The following is a description of a gene set: Any process that modulates the rate, frequency or extent of keratinocyte proliferation. Keratinocyte proliferation is the multiplication or reproduction of keratinocytes, resulting in the expansion of a cell population. species: Mus musculus Mouse Gene Set: GOBP_REGULATION_OF_KERATINOCYTE_PROLIFERATION, and this is the list of marker genes: Irf6, Med1, Kdf1, Klf9, Fgfr2, Ift80, Lrg1, Tgm1, Bcl11b, Ift172, Ovol1, Crnn, Ptprk (protein tyrosine phosphatase receptor type K), Intu, Prkd1, Nfatc1, Efnb2, Kif3a, Trp63, Ctsl, Snai2, Ift122, Slurp1, Mdk, Notch2, Reg3a, Ift88, Eppk1, Extl3 (exostosin-like glycosyltransferase 3), Ift74, Vdr, Ovol2, Sfn (NCBI Gene Id 55948), Fgf10, Stxbp4, Cdh3 (cadherin 3), Reg3g, Srsf6, Has2, Gpr15lg, Fgf7, Cask, Ptch1, Zfp36, Yap1, Cd109, Twist2 (twist basic helix-loop-helix transcription factor 2), Zeb1, Ift57, Ift52, Zfp36l1